The following is a description of a gene set: studied in species Mus musculus Mouse Gene Set: GOBP_POSITIVE_REGULATION_OF_RNA_METABOLIC_PROCESS Any process that activates or increases the frequency, rate or extent of the chemical reactions and pathways involving RNA., and this is the list of marker genes: Zfp143, Ehf, Cdk5rap2, Wnt10b, Ddx3x, Zc3h12d, Nanog, Spag8, Mad2l2, Map3k5, Sox9, Fgf7, Usp22, Psip1, Rhoq, Cbx7, Pou2af3, Ctcfl, Taf1, Hoxb5, Eif4a1, Dvl3, Fhl5, Prdm15, Tfap2d, Cd81, Myrfl, Lpin3, Pmf1, Ccpg1, Il33, Lum, Cd38, Trim13, Neurod6, Clock, Trim24, Qrich1, Creb3l3 (NCBI Gene Id 52152), Hoxc10, Tlr2, Med30, Barx2, Pkp1, Tra2b, Itga6, Nr6a1, Cebpz, Tcea1, Pbx2, Mycbp, Pax5, Il10, Arnt2, Itga8, Crebrf, Hmx2, Creb3, Bnc1, Wac, Ucn, Foxo1, Nr4a1, Tfap2e, Cnbp, Hoxa1, Ep400, Slc39a5 (solute carrier family 39 (metal ion transporter), member 5), Myf5, Nif3l1, Sox10, Rbmx (NCBI Gene Id 19655), Med15, Shc1, Cdc5lrt7, Pik3r1, Ecd, Bud23, Tnf, Ccnb1, Psmc6, Nfatc1, Mir744, Olig2, Dlx6os1, Mycs, Mavs, Zmiz2, Prrx1, Nodal, Arid2, Zfp715, Sertad3, Fank1, Meis3, Med7, Ces1d, Med6, Ogg1, Prkn, Churc1, Esr1, Il6, En1, Serpinf2, Efcab7, Msl3, Cep290, Wnk1, Sirt3, Mapk9, Zfp335, Med24 (mediator complex subunit 24), Nmd3, Ebf2, Usf1, Setd4, Tbx22, Atxn7, Pou1f1, Mak, Zfp36l1, Lef1, Pogz, Alx1, Pus1, Arid1a, Nanos1, S100a10, Cnot7, Ccn1, Tut4, Foxj3, Cd274, Zbtb48, Setd7, Bmp3, Bhlhe23, Mir196a-1, Runx2, Map2k2, Mlh1, Irx6, Grsf1, Rfx6, Acvr1, Olig3, Rnasel, Lmo4, Nufip1, Il4i1, Pdgfb, Trp53, Kdm4c, Sox2, Cdkn2a, Med31, Dcp1a, Mapkapk5, Foxa2, Srebf2, Taf4, Irf6, Patz1 (NCBI Gene Id 80645), Hoxd4, Gsk3a, Tet3, Kcnh2, Tfpt, Ilk, Rb1, Foxl2, Wdr77, Rreb1, Sirt1, Foxm1, Apbb1, Trp53inp1, Sox14, Rigi, Foxd2 (NCBI Gene Id 17301), Sting1, Trim71, Ss18l1, Atm, App, Cela1, Tlx1, Tcea2, Prdm2, Nsd1, Myf6, Ikbkg, Bmp5, Twist1, Ywhah, Cenpj, Ell2, Ascl1, Mir196a-2 (microRNA 196a-2), Glis3, Bloc1s2, Nr5a1, Phf5a, Sall1, Ankrd49, Mospd1, Zfp646, Ppp1r15a, Smarcad1, Ddx5, Heatr1, Tbx19, Foxn4 (NCBI Gene Id 243222), Nr1h5, Gtf2f2, Hivep2, Neurog2, Atf1-ps (activating transcription factor 1, pseudogene), Purb, Rnf10, Phox2a, Sox11, Meis2, Mcf2l, Bex2, Egr4, Prop1, Mta1, Pitx1, Pitx3, Hoxa7, Cdkn1c, Rgcc, Sp100, Topors (topoisomerase I binding, arginine/serine-rich), Dis3l2, Ppm1a, Msl1, Creb3l1 (cAMP responsive element binding protein 3-like 1), Slirp, Ino80e, Htatip2, Med17, Mical2, Klf12, Wbp2nl, Csrnp1, Met, Sra1, Scx, Ctcf, Ifi207, Dyrk1b, Ctbp2, Sub1, Rprd1b, Eapp, Rbpj, Klf2, Shh, Pou2af1, Cenpk, Rbpjl, Osr2, Lif, Zfp711 (NCBI Gene Id 69243), Btrc, Usf2, Camta2, Ube3a, Elf5 (E74-like factor 5), Gal, Hmbox1, Nrip1, Rfx7, Cxcr3, Zfp423, Caprin1, Rara, Mybl1 (myeloblastosis oncogene-like 1), Kmt2a, Foxp3, Alkbh5, Esrrg, Trim25, Zfp819, Sox30, Hoxd3 (homeobox D3), Pum1, Gsk3b, Cdk13, Zic1, Atf4, Ruvbl1, Kdm3a, Snip1, Pou4f2, Upf1, Xpa, Jpx, Aym1, Nsd3, Gcm2, Gdnf, Jmy, Qki, Spen, Cxxc1, Irf1, Atoh8, E2f2 (NCBI Gene Id 329958), Bmpr1b, Dek, Gsdmd, Prdx6b, Fzd1, Supv3l1, Bcl2l12, Gm7324, Atxn7l3, Zfp609, Smad9, Crx (cone-rod homeobox), Xrcc6, Ckap2, Zfp131, Dvl2, Fgf23, Hes1, Vgll2, Celf1, Celf3, Zfp142, Ppp3cb (NCBI Gene Id 66215), Epo, Lin28b, Ago2, Ifi203 (interferon activated gene 203), Smad1, Dot1l, Fbln5, Tnip1, Rfx5, Cdk7, Tcf7l1, Ubtfl1, Taf3, Nol11, Usf3, Snai1 (NCBI Gene Id 98875), Edn1, Med20, Mir196b, Ifrd1, Foxc2, Afap1l2, Neurod4, Yaf2, Bmal2, Jup, Med23, Cd4, Cops5, Ppp2r5b, Cdc73, Kansl1, Jun, Mir466d, Nkrf, Hnrnpr, Arl2bp, Arhgef11, Cebpd, Fxr2, Per2, F2r, Plac8, Preb, Zfp239, Lpin2, Nr1i3, Psrc1, Zglp1, Ifi206, Relb, Mecom, Mir143, Edrf1, Otx2, Zxdb, Trmt112, Figla, Fgf10, Msantd1, Spin1, Brd4, Il17f, Tbx4, Prox1, Mtdh, Setd3, Mta2, Sirt2, Fzd4, Rbmyf1, Apln, Cdx1, Epc1, Brf1, Yeats4, Tfap2c, Pax2, Pcgf5, Hand2, Zfp287, Zeb2, Akirin1, Ptbp1, Rfxank, Ap3d1, Ccnt2, Dab2, Olig1, Prkcb, Map2k3, Samd4, Prdm10, Trim62, Klf15, Ahr, Sox3, Trim8, Dtx3l, Cdc5lrt9, Eng, Foxp1, Cited4, Tet1, Bcl3, Sik2, Rbm39, Gigyf2, Crlf3, Sox21, Eaf1, Psen1, Med14, Khsrp, Rere (arginine glutamic acid dipeptide (RE) repeats), Satb2, Ppara, Egr1 (early growth response 1), Kdm7a, Tent4a, Morf4l2, Ccna2, Ash2l (ASH2 like histone lysine methyltransferase complex subunit), Maz, Actb, Mitf (NCBI Gene Id 17342), Gata2, Chchd2, Pik3r2, Tcf20, Chd8, Zbtb7c, Sertad1, Hlf, Ogt, Ablim1, Kmt2d, Ror2, Ywhab, Neurod1, Rida, Actr2, Hoxb2, Hax1, Mapre3, Jak2 (Janus kinase 2), Ncl, Sf3b3, Tfe3 (NCBI Gene Id 21424), Sf3b1, Mrpl12 (NCBI Gene Id 69758), Vdr, Eif1, Ldb2, Mesp1, Zeb1, Fzd5 (NCBI Gene Id 98335), Arid5b, Npas3, Yy1, Taf8, Scaf8, Ddx17, Morf4l1, Slc9a1, Tert, Wnt5a, Stat6 (NCBI Gene Id 216450), Mef2d, Zfp318, Atn1, Wnt6 (wingless-type MMTV integration site family, member 6), Bmal1, Thrb, Mmp12, Mt3, Cbfb, Nucks1, Hoxa2 (NCBI Gene Id 15399), Ilf3, Glis1, Fam170a, Nfyb, Tead1, Foxk2, Nr2f2, Dmrt2, Prrx2, Ebf4, Chchd2-ps, Gtf2f1, Sox4, Stat4, Usp21, Lmntd2, Nkx2-2, Arhgef2, Nkx2-3, Tbl1xr1, Irf7, Zfp523, Tesc, Hoxa5, Msgn1, Tgfb2, Rptor, Per1, Ddn, Snx5, Raf1, Riok2, Med18, Nfyc, Fgf1, Zbtb17, Sohlh1, Hes6, Tada3, Zfp639, Utf1, Mkx, Lrp6, Rybp-ps, Armcx3, Hoxb1, Ncoa3, Pax7, Csf3, Fstl3, Hoxc13, Rnf40, Nos1, Taf10, Wdr5, Wwtr1, Wnt7a (wingless-type MMTV integration site family, member 7A), Ascl5 (NCBI Gene Id 226439), Hmga2, Niban2, Nr4a3, Evx1, Gtpbp1, Ifi203-ps, Wwox (NCBI Gene Id 93829), Mtor, Hey1, Npas2, Arap1, Cdk12, Actn2, Paxbp1, Srebf1 (NCBI Gene Id 276754), E2f1, Ikzf4, Zfp64, Fto, Fzd7, Ing3, Zscan2, Btg2, Tfec, Bmpr1a, Dab2ip, Igf1, Ascl3, Hoxd8, Nck1, Atrx, Dlx5, Zic5, Kansl2, Sirt7, Hdac5, Zp3, Capn3, Wwc1, Skap1, Heyl, Nfkb2, Gtf2a1, Pou5f1, Nck2, Neurog1, Ski, Rfx4, Reno1, Gsx1, Zfp36l3, Etv4, Rnf187, Cdc5lrt1, Gata1, Fus, Parn, Plscr1, Nkx2-6, Tnrc6c, Tnrc6a, Med9, Zc3h18, Cavin2, Tnrc6b, Epc2, Prdm9, Ascl2, St18, Smo, Fzd2, Nup62, Hexb (hexosaminidase B), Rc3h1, Hivep1, Zfp384, Foxi1, Tbx2, Muc1, Ssbp3, Nfe2l2, Spp1, Irf5, Zfp750, Stat5a, Celf4, Wwp2, Drd2, Ptf1a, Lmx1a, Bcl11b, Hif1a, Six1, Myt1l (myelin transcription factor 1-like), Smad6, Hes3, Taf5l, Ccnt1, Rbpms, Thrap3, Brpf1, Tsc2, Lmo7, Inhba, Ankrd1, Brca1, Rora, Ncoa7, Gli3, Zfpm1 (zinc finger protein, multitype 1), Grhl2, Esr2, Rps6ka3, Actl6a, Tbk1, Gdf7, Trim32, Nr1h3, Hmgb2, Hnrnpd, Csde1, Bambi, Nfix, Lhx5, Cytl1, Bhlhe22, Six5, Nolc1, Myb, Galr2, Ikzf2, Cnot6, Pomc (NCBI Gene Id 18976), Ddrgk1, Zc3hav1, Osm, Actn1, Ino80, Ift74, Pou2f2, Txk, Tfap4, Myocd (NCBI Gene Id 214384), Atf3, Myo1c, Ccar1, Tsc22d1, Ss18, Med28, Lrp5, Zxdc, Pkd1, Ptprn, Stat5b, Ikbkb, Jund, Npas4, Zfat, Agrn, Mms19, Gata3, Ifi208, Trim28, Hinfp, Senp2, Smarca2, Mef2a, Smarcb1, Nfatc2, Fhod1, Foxa1, En2, Cdx4, Pcbp2, Aatf, Hnf4a, Cdk5rap3, Cdk9, Zic2, Prl, Hoxd13, Mir103-2, Plekhn1, Tgfb1, Hoxc11, Ppp1r12a, Pcbp1, Mllt1, Fosb, Mrtfb, Klf6, Id2, Tdrd3, Nfkb1, Onecut1 (one cut domain, family member 1), Mrgbp, Nr5a2, Actn4, Pparg, Bicral, Rel, Zfp90, Med22, Ebf1, Zfhx3, Zfp42, Gtf2h1, Hhex, Gtf2a2 (NCBI Gene Id 83601), Tgfb3, Pcbd2, Nr0b2, Atf2, Abra, Il18, Mapk3, Npm1, Smarca5, Mir451b, Fgfr2, Supt6, Ablim3, Gata6, Cdk8, Eif4enif1, Actr5, Pgr, Cdc5l, Nr1d2, Stat1, Rock1, Tbx18, Tead4, Med8, Picalm, Bmp10 (NCBI Gene Id 12154), Etv1, Brd7, Nfil3, Ercc6, Bhlha15, Creb1, Tunar, Ing4, Pou4f3, D1Pas1, Nkx3-1, Zfp212, Mllt3, Tfr2, Foxk1, Uchl5, Ruvbl2, Rorb, Pdx1, Atf7 (NCBI Gene Id 77354), Sfrp1, Msl2, Senp1, Hoxd10, Exosc9, Csrnp3, Ddx11, Il25, Supt4b, Atad2, Stra8, E4f1 (E4F transcription factor 1), Cebpg, Xbp1, Ptma, Fadd, Inpp5k, Bmp6, Zmiz1, Mybbp1a, Hltf, Paip1, Fezf2, Rbmy, Tfeb, Tcerg1, Gtsf1, Fosl1 (NCBI Gene Id 14283), Piwil4, Piwil2, Ppard, Elavl1, Thap3, Nr1i2, Elk3, Elk1, Pfn1, Bcl10, Clns1a, Tal1, Prkdc, Il1b, Mybl2, Tlr4, Rrn3, Rad54l2, Cdk2, Atmin, Foxf2, Pprc1, Zc3h8, Rc3h2, Top2b, Cys1, Tnfsf8, Arnt, Med1, Brca2, Sox18, Atoh7, Parp1, Mbd2 (NCBI Gene Id 17191), Cask, Rapgef3, Rbbp4, Arrb1, Dnajc2, Akirin2, Fiz1, Sox8, Grhl3, Sall2, Arid4a, Tbx20 (T-box 20), Ets1, Mbtps2, Bcl9, Pax3, Nobox, Trp53bp1, Cdc5lrt10, Gabpb1, Yes1, Cdh13, Foxo3, Tefm, Noct, Mlx, Mir144, Rtraf, Maged1, Ddx41, Kdm6a, Galr3, Zkscan17, Elf1, Fgf4, Grem1, Id4, Tcf3, Bmp7, Tet2, Foxe1, Grhl1, Phox2b, Egr2, Tlx2 (NCBI Gene Id 545897), H2az1, Pwwp2b, Rock2, Pitx2, Trp53inp2, Eif4a3, Jak3, Slc30a9, Kat5 (NCBI Gene Id 81601), Mrtfa, Taf6l, Esrra, Cdh1, Mapk15, Tbp, Syncrip, Ret, Irx4, Jade1, Smyd3, Nup98, Fos, Arid4b, Hand1, Hcls1, Gatad2a, Nrf1, Kat2a, Blm, Utp15, Tada2a, Daxx, Kat7, Cdc5lrt5, Chd6, Klf13, Irf4, Dhx36, Vsx2, Med12l, Crtc1, Klf9, Creb3l4, Gdf6, Elf4, Zfp36, Nr2c2, Vezf1, Foxn1, Ep300, Atf7ip, Myt1, Ttc5, Ice1, Adrb2, Sgf29, Il2, Leo1, Hnrnpu, Chek2, Ptms, Epcam, Klf1, Zfp521, Taf13, Ikzf1, E2f8, Larp7-ps, Mapk1, Chd7, Mc1r, Dll1, Ghrh, Hmgb1, Six4, Irf2, Prdm5, Map2k7, Patl2, Cited1 (NCBI Gene Id 12705), Tnip2, Prdm16, Foxa3, Dazap1 (NCBI Gene Id 70248), Hnrnpab, E2f4, Pdlim1, Zfp148, Taf5, Yy2, Dcp1b, Prkd2, Trim27, Bcas3, Ube2e1, Mars1, Rybp, Nog, Egln1, Map3k1, Insr, Hdac1, Cdc5lrt4, Cpeb3, Kat2b, Irf3, Foxf1, Ing1, Bmp4, Pim1, Hnf1a, Tbx21, Mecp2, Ino80c, Creb3l2, Pih1d1, Ythdf2, Cnot9, Gli1, Spx, Nfat5, Fezf1, Ssbp4, Ar, Kdm6b, Tbx3, Zfp292, Tlr7, Nr3c1, Dmtf1, Hivep3, Slc38a3, Dbp, Cd40, Dyrk1a, Zbtb18, Cdon, Phip, Ifnb1, Il4 (NCBI Gene Id 16189), Acss2, Hif3a, Spi1, Pf4 (NCBI Gene Id 56744), Myd88, Wdr75, Tbl1x, Nfatc4, Rbm24, Nupr1, Etv5, Tfam, Maml2, Plagl1, Pkm, Mcrs1, Dxo, Tbx15, Top2a, Abhd14b, Tgfb1i1, Ripk1, Aire, Csrp3, Irf2bpl, Rap2c, Gata5, Smad2, Mef2b, Tcf4, Aamdc, Kansl3, Galr1, Dlx3, Mycn, Med19, Ctnnb1, Prl2c2, Pax1, Mettl3, Klf10, Igf2, Zbtb16, Maf, Sohlh2, Tbx1, Tcf21, Mesp2, Sfrp2, Ppp3ca, Dlx1, Dcp2, Prr5l, Ebf3, Osr1, Sp1, Pink1, Etv2, Notch1, Glis2, Sfr1, Isl1, Bud31, Ell, Apbb2, Hnf1b, Ntf3, Maml3, Med10, Fbxw11, Six2, Tead3, Hes5, Wt1, Elf2, Ubp1, Hdac2, Ppargc1b, Zfp593 (NCBI Gene Id 68040), Rbmyf3, Ino80d (INO80 complex subunit D), Nkx2-5, Chuk, Apoe, Maff, Nfatc2ip, Batf, Pfkm, Ubtf, Ier5, Lmx1b, Zfp281, Lyl1, Tnfrsf1a, Cebpa, Pkd2, Dlx2, Il13, Notch2, Chd4, Mamstr, Neurod2, Casz1, Pbrm1, Trim14, Igf1r, Rnf20, Pkn1, Tox3, Zfp24, Gcm1, Adarb1, Pias1, Banp, Prpf6, Actr8, Pan2, Bmpr2, Arid3c, Crem, Sf3b5, Acvrl1, Ago1, Stk16, Ccdc62, Pou2f1, Zbtb38, Hmga1, Rxrg, Ddit3, Tmf1, Zbed4, Mysm1, F2rl1, Cnot8, Trerf1, Foxj2, Setx, Nr2f1, Sfpq, Hoxb7 (homeobox B7), Erbb4, Rbck1, Dnd1, Akt2, Phf8, Col1a1, Ybx1, Crebbp, Vegfa, Ankrd23, Nelfa, Nkx2-1, Rbmyf6, Supt7l, Asph, Rfx3, Tent4b, Kdm5a, Zfp175, Tasp1, Tlr9, Smarca1, Esrrb, Cand1, Gli2, Mex3d, Gper1, Ell3, Nlrp3, Foxr1, Lhx3, Mstn, Apobec1, Pknox1, Tmsb4x, Pml, Calcoco1 (NCBI Gene Id 67488), Naa15, Ctr9, Med12, Rrp1b, Grin1, Spz1, Nkx6-3, Nfia, Taf7 (TATA-box binding protein associated factor 7), Nr1h2, Sry, Hyal2, Med26, Taf12, Zfp541, Myod1, Cebpe, Nr3c2, Fev, Nmnat1, Nanos3, Trp63, Asxl2, Ino80b, Supt4a, Park7, P2rx2, Tnfsf11, Eef1d, Zbed3, Nup85, Smarcc1, Rxra, Prpf19 (NCBI Gene Id 28000), Samd4b, E2f5, Spdef, Pou4f1, Kdm1a, Rasl11a, Mzf1, Notch4, Trim37, Smarca4, Egr3, Crebzf, Foxh1, Zbtb7b, Egf, Ifnar1, Rbm3, Tfdp2, Pck1, Myrf, Piwil1, T, Il11, Ago3, Gnl3, Eif2ak3, Tnni2, Smad5 (NCBI Gene Id 76327), Zbtb49, Mydgf, Prkaa1, Zfp395, Nhlh1, Dmrt1, Msx1, Edf1, Rgmb, Triap1, Nr4a2, Ciita, Pou3f1, Sost, Zfp263, Men1, Wdr43, Tex24, Gbx2 (gastrulation brain homeobox 2), Prdm11, Wnt3a, Hdac3, Meis1, Lmo3, Gata4, Gpbp1, Hsf3, Pcbd1, Mllt10, Wnt1, Rnf4, Zscan21, Neurog3, Elk4, Nr2e1, Cebpb, Sox12, P2ry1, Pabpn1l, Klf4, Nek4, Il22, Rbm15, Cir1, Ccl3, Foxc1, Mllt11, Plcb1, Psmc3ip, Max, Mbd3, Tlr3, Dcaf6, Pnpt1, Thap11, Dvl1, Pagr1a, Zfp410, Igbp1, Agap2, Ezh1, Rax, Sox6, Nkx2-9, Cnot6l, Nipbl, Pin1, Rxrb, Nfkbia, Six3, Jag1, Akna, Helt, Ier2, Klf7, Cd28, Pde12, Mef2c, Tfdp1, Lhx2, Hnf4g, Carf, Ncoa2, Phf2 (NCBI Gene Id 18676), Bcl9l, Rarb, Smad4, Zfp462, Gdf2, Eaf2, Polr2g, Rbmxl2, Cdc5lrt8, Mdk (midkine), Nr1h4, Rfc1, Kars1, Prdm4, Maml1, Taf6, Slc11a1, Otx1 (NCBI Gene Id 18423), Mlxipl, Ptch1, Sbno2, Wnt4, Asxl1, Ifi214, Il17a, Wnt11, Tacc1, Foxd1, Tfcp2 (NCBI Gene Id 319662), Nfic, Tbr1, Rhog, Jmjd6, Bicra (NCBI Gene Id 546025), Spib, Sox1 (SRY (sex determining region Y)-box 1), Atf1, Med4, Itgb1bp1, Eya1, Npat, Agt, Rnf6, Taf9, Bsx (brain specific homeobox), Rarg, Exosc10, Rnf14, Pcid2, Creb5, Mixl1, Cx3cl1, Iqce, Gatad2b, Irf9, Zfp407 (zinc finger protein 407), Paxip1, Ets2, Flt3l, Mtf1 (NCBI Gene Id 17764), Bclaf1, Carm1, Kdm8, Ccnk, Dimt1, Fgf2, Lbh, Hamp, Stat3, Nanos2, Foxo4, Hoxa4, Ptov1, Nfatc3, Crebl2, Pbx3, Mga, Hnrnpk, Sgsm1, Fli1, Stat2, Mettl23, Dcps, Gpatch3, Larp7, Map2k1, Usp16, Mir7578, Ifi213, Mafg, Rit2, Glmp, Cnot1 (CCR4-NOT transcription complex, subunit 1), Arid5a, Patl1, Gpbp1l1, Sox15, Ythdf3 (YTH N6-methyladenosine RNA binding protein 3), Sall4 (spalt like transcription factor 4), Zcchc12, Hoxb3, Arid3a, Gmeb1, Foxj1, Acvr2a, Obi1, Hdac4, Nrbf2, Hcfc1, Rfx2, Pou3f2, Strn3, Hjv, Safb, Cited2, Kat8, Xpc, Eomes, Mir451a, Ndn, Atf6, Dcn, Mllt6, Ilf2, Atoh1, Trip4, Pth, Hmgn3, Drd3, Mafb, Btbd18, Epas1, Ncbp2, Med13, Birc2 (baculoviral IAP repeat-containing 2), Pygo1, Nfya, Ppp3r1, Ptges2, Ang, Bmp2, Med27, Zfp516, Spic, Lpin1, Dicer1, Pan3, Rgma, Gmeb2, Camk4, Ythdf1, Lyar, Akap8l, Rfxap, Ube2l3, Hoxb4, Fosl2, Ncbp1 (nuclear cap binding protein subunit 1), Prkd1, Tra2a, Hoxb9, Ngfr, Il1a, Mkrn2, Tox, Myog, Rest, Il23a, Myc, Trim38, Thra, Rps6ka1, Paf1, Smarcc2, Klf14, Rbm14, Wasl, Zic3, Tcf7l2, Nlrc5, Peg3, Map2k5, Rela, Tbx5, Mettl16, Parp9, Adcyap1, Zswim8, Fxr1, Sumo2, Zmynd8, Smarcd3, Tnfrsf1b, Arid1b, Tbx6, Rorc, Cripto (cripto, EGF-CFC family member), Chp2, Coq7, Zfx, Taf11, Tbx10 (T-box 10), Zfp36l2, Med16, Pax9, Crtc2, Gabpa, Tnks (tankyrase, TRF1-interacting ankyrin-related ADP-ribose polymerase), Bmyc, Lmo1, Nod2, Has3 (hyaluronan synthase 3), Hoxa13 (homeobox A13), S1pr1, Pwp1, Pbxip1, Mov10, Nfrkb, Cdx2, Agtr2, Med21, Ablim2, Mndal, Nfkbiz, Phb1, Med11, Cnot2, Arglu1, Onecut3, Ifi209 (NCBI Gene Id 98348), Upf3a, Ddx21, Nampt, Ing2, Slc40a1, Fgf9, Snrnp70, Zfpm2, Riok1, Kpna6, Hsf1, Lhx1, Foxd3, Pwwp2a, Zfp326, Znhit1, Hipk2, Barhl1, Zfp758, Brd3 (bromodomain containing 3), Auts2, Yap1, Etv6, Kat6a, Tmprss6, Hsf5, Hoxa11, Kmt2c, Pbx1, Ash1l, Cavin4, Trim44, Tut7, Pelp1, Arx, Hdgf, Notch3 (NCBI Gene Id 18131), Hoxa10, Tfap2b, Mcidas, Pax8 (paired box 8), Bmp15, Pnldc1, Srf, Mdfic, Arf4, Hoxd9, Pid1, Sp3, Gtf2i, Tcf15, Meaf6, Plag1, Pou2f3, Ssbp2, Meox2, Med25, Crtc3, Camta1, Mepce, Nfe2l1, Cirbp, Nhlh2, Kmt2e, Ippk, Mapk7, Snw1, Irx3, Apex1, Tfap2a, Junb, Tob1, Nfib, Sertad2, Npnt, Sp7, Prmt5, Psmd9, Irf8, Ice2 (interactor of little elongation complex ELL subunit 2), Traf6, Pin1rt1, Bptf, Onecut2, Mettl14, Atf6b, Wnt2, Ifng, Cd74, Dhx33, Aff1, Ldb1, Ncoa1, Mta3, Scand1, Ncoa6, Zfp677, Lhx4, Ihh, Ovol2, Asxl3, Ppp2r5d, Rbmxl1, Was, Pou3f3, Mafa, Deaf1, Supt5, Pbx4, Helz2, Prmt2, Atxn1, Taf4b, Igf2bp1, Tef, Rps6ka4, Hoxc4, Pou2af2, Rsf1, Phf20, Ndp, Actr3 (NCBI Gene Id 74117), Tada1, E2f3, Csrnp2, Eny2, Zfp827, Akt1, Pabpc1, Brd8, E2f7, Actr6, Tox2, Nr1d1 (nuclear receptor subfamily 1, group D, member 1), Erbb2, Runx3, Pias2, Ercc1, Erg, Nme2, Elf3, Fgfr1, Nr2e3, Tardbp, Hspa8, Med29, Trf, Caprin2, Zfp219, Mapk14, Hsf2, Rbbp7, Mir466l, Supt20, Prdx6, Glp1r, Camk1, Wbp2, Nrl, Map3k12, Tead2, Rhox5 (NCBI Gene Id 18617), Zc3h12a, Cdc5lrt6, Ppargc1a, Atf5, Barhl2, Ccnc, Nelfe, Pithd1, Bach1, Hmga1b, Lmo2, Kmt2b, Zkscan3, Dhx9, Gabpb2, Mlxip, Trp73, Hey2, Vps72, Pax6, Gps2 (NCBI Gene Id 56310), Tescl, Plagl2, Bclaf3 (NCBI Gene Id 69649), Ikzf3, Il5, Ahi1, Rai1, Cnot3, Rps6ka5, Meox1, Klf5, Trrap, Alx4 (NCBI Gene Id 11695), Macc1, Egfr, Taf2, Lsm1, Tcf12, Pim2, Ap3b1, Runx1, Smad3, Rbmyf9, Mbtd1, Kat6b, Litaf, Sox7, Tgfbr1, Fubp3, Isl2, Acvr1b, Hras, Mir103-1, Hoxa9 (homeobox A9), Arid3b, Dmap1, Upf3b, Anxa2, Sox17, Baz1b